The following is a description of a gene set: Neighborhood of TYK2 tyrosine kinase 2 in the GNF2 expression compendium Neighborhood of TYK2 Human Gene Set: GNF2_TYK2 species: Homo sapiens, and this is the list of marker genes: CORO7, ADPGK (ADP dependent glucokinase), LRRFIP1, CYBC1, LCP1, CHD1, NCKAP1L, ARPC1B, MANBA, EIF1, PAK2, USP3, ACTR2, CDV3, ARHGAP4, PSMB10, DDX5, ARHGDIB, BNIP2, STAT6, HCLS1, CORO1A, FAM120A, MOB1A, TYK2, DDX3X, PAPOLA, GDI2, PHF21A, ELF4, DOCK2, GRK6, HEATR3